The following is a description of a gene set: Human Gene Set: GOBP_RESPONSE_TO_HYDROSTATIC_PRESSURE species: Homo sapiens Any process that results in a change in state or activity of a cell or an organism (in terms of movement, secretion, enzyme production, gene expression, etc.) as a result of a hydrostatic pressure stimulus. Hydrostatic pressure is the force acting on an object in a system where the fluid is at rest (as opposed to moving). The weight of the fluid above the object creates pressure on it., and this is the list of marker genes: ATP2B4 (NCBI Gene Id 54594), PLEC, PKD2 (NCBI Gene Id 5311), COL18A1, PIK3CA, NTRK1